Given this list of marker genes SLC25A19 (solute carrier family 25 member 19), TPK1, THTPA, SLC19A2, SLC19A3, here is a description of the gene set: Reactome Pathway: Vitamin B1 (thiamin) metabolism studied in species Homo sapiens Vitamin B1 (thiamin) is found naturally in certain foodstuffs such as green peas, spinach, liver, bananas, whole grains and legumes. Human diseases associated with thiamin deficiency include beriberi, due to a thiamin-deficient diet, TMRA, due to defects in the SLC19A2 transport protein, and Wernicke-Korsakoff Syndrome, associated with thiamin deficiency in alcoholism. Thiamin is water-soluble so is not stored in the body. When pyrophosphorylated, thiamin is converted into the coenzyme thiamin pyrophosphate (ThPP, codecarboxylase) which plays an essential role in oxidative decarboxylation and group transfer reactions. part of: Metabolism of water-soluble vitamins and cofactors